Given this list of marker genes MLC1, TRABD, HDAC10, BRD1, MOV10L1, TTLL8, PIM3, MAPK12, SELENOO, IL17REL, ZBED4, PLXNB2, CRELD2, MAPK11, ALG12, PANX2, TUBGCP6, here is a description of the gene set: studied in species Homo sapiens Human Gene Set: NIKOLSKY_BREAST_CANCER_22Q13_AMPLICON A single cancer cell contains large numbers of genetic alterations that in combination create the malignant phenotype. However, whether amplified and mutated genes form functional and physical interaction networks that could explain the selection for cells with combined alterations is unknown. To investigate this issue, we characterized copy number alterations in 191 breast tumors using dense single nucleotide polymorphism arrays and identified genes with copy number gain organized into 30 amplicons. Amplicons were distributed unequally throughout the genome. Each amplicon had distinct enrichment pattern in pathways, networks, and molecular functions, but genes within individual amplicons did not form coherent functional units. Genes in amplicons included all major tumorigenic pathways and were highly enriched in breast cancer-causative genes. In contrast, genes with somatic mutations in breast cancer were distributed randomly over the genome, did not represent a functionally cohesive gene set, and were relatively less enriched in breast cancer marker genes. Mutated and gained genes did not show statistically significant overlap but were highly synergistic in populating key tumorigenic pathways including transforming growth factor beta, WNT, fibroblast growth factor, and PIP3 signaling. In general, mutated genes were more frequently upstream of gained genes in transcription regulation signaling than vice versa, suggesting that mutated genes are mainly regulators, whereas gained genes are mostly regulated. ESR1 was the major transcription factor regulating amplified but not mutated genes. Our results support the hypothesis that multiple genetic events, including copy number gains and somatic mutations, are necessary for establishing the malignant cell phenotype. from publication Nikolsky Y, Sviridov E, Yao J, Dosymbekov D, Ustyansky V, Kaznacheev V, Dezso Z, Mulvey L, Macconaill LE, Winckler W, Serebryiskaya T, Nikolskaya T, Polyak K (PMID 19010930) Genes within amplicon 22q13 identified in a copy number alterations study of 191 breast tumor samples.